Given this list of marker genes Larp1, Akt1s1, Mtor, Mlst8, Tti1, Rptor, here is a description of the gene set: Mouse Gene Set: GOCC_TORC1_COMPLEX A protein complex that contains at least TOR (target of rapamycin) and Raptor (regulatory-associated protein of TOR), or orthologs of, in complex with other signaling components. Mediates the phosphorylation and activation of S6K. In Saccharomyces, the complex contains Kog1p, Lst8p, Tco89p, and either Tor1p or Tor2p. species: Mus musculus